Given this list of marker genes PLXDC1, PSMB3, CASC3, EFCAB5, KRT28, MED1, NEK8, GOSR1, SYNRG, ERAL1, KRTAP4-1, STARD3, CSF3, ABHD15, SPAG5, SMARCE1, KRTAP4-5, MSL1, BLTP2, THRA, SPMAP1, ACACA, TOP2A, PHF12, TADA2A, RAB34, KRTAP4-3, NSRP1, RPL19, KRT27, TMIGD1, TMEM98, KRT24, MYO1D, CCL4, FLOT2, RPL23A, MRPL45, KRT12, CWC25, PIPOX, PROCA1, PCGF2, GPR179, SLC46A1, KRTAP4-4, TAOK1, GRB7, CRYBA1, RAPGEFL1, TRAF4, PNMT, ASIC2, MLLT6, NEUROD2, MED24, WIPF2, PSMD3, SLC13A2, SOCS7, DHRS13, IKZF3 (NCBI Gene Id 22806, IKAROS family zinc finger 3), STAC2, KRT26, CPD, GSDMB, KRT10, NUFIP2, SDF2, KRT25, SSH2, FAM222B, C17orf78, CCR7, ERBB2, RARA, RPL23AP42, UNC119, SRCIN1, PPP1R1B, NR1D1 (nuclear receptor subfamily 1 group D member 1), GJD3, FBXL20, RSKR, CCL3, GIT1, ANKRD13B, ALDOC, MYO18A, TNS4, CORO6, SUPT6H, LASP1, MIEN1, TBC1D3F, GSDMA, PGAP3, SLC6A4, KRT10-AS1, KRT20, CDC6, ZPBP2, PIP4K2B, KRTAP9-8, CCL2, RPL23, KRTAP9-4 (keratin associated protein 9-4), KRTAP4-2, TLCD1, KRT222, HNF1B, TBC1D29P, FBXO47, BLMH, FOXN1, DDX52, KRT23, CACNB1, IGFBP4, CCL18, TP53I13, PIGS, ORMDL3, TCAP, CDK12, DUSP14, SEZ6, KRTAP9-3, KRTAP9-2 (keratin associated protein 9-2), CCL23, SPACA3, SARM1, here is a description of the gene set: Human Gene Set: NIKOLSKY_BREAST_CANCER_17Q11_Q21_AMPLICON from publication Nikolsky Y, Sviridov E, Yao J, Dosymbekov D, Ustyansky V, Kaznacheev V, Dezso Z, Mulvey L, Macconaill LE, Winckler W, Serebryiskaya T, Nikolskaya T, Polyak K (PMID 19010930) studied in species Homo sapiens Genes within amplicon 17q11-q21 identified in a copy number alterations study of 191 breast tumor samples. A single cancer cell contains large numbers of genetic alterations that in combination create the malignant phenotype. However, whether amplified and mutated genes form functional and physical interaction networks that could explain the selection for cells with combined alterations is unknown. To investigate this issue, we characterized copy number alterations in 191 breast tumors using dense single nucleotide polymorphism arrays and identified genes with copy number gain organized into 30 amplicons. Amplicons were distributed unequally throughout the genome. Each amplicon had distinct enrichment pattern in pathways, networks, and molecular functions, but genes within individual amplicons did not form coherent functional units. Genes in amplicons included all major tumorigenic pathways and were highly enriched in breast cancer-causative genes. In contrast, genes with somatic mutations in breast cancer were distributed randomly over the genome, did not represent a functionally cohesive gene set, and were relatively less enriched in breast cancer marker genes. Mutated and gained genes did not show statistically significant overlap but were highly synergistic in populating key tumorigenic pathways including transforming growth factor beta, WNT, fibroblast growth factor, and PIP3 signaling. In general, mutated genes were more frequently upstream of gained genes in transcription regulation signaling than vice versa, suggesting that mutated genes are mainly regulators, whereas gained genes are mostly regulated. ESR1 was the major transcription factor regulating amplified but not mutated genes. Our results support the hypothesis that multiple genetic events, including copy number gains and somatic mutations, are necessary for establishing the malignant cell phenotype.